The following is a description of a gene set: Human Gene Set: MIR600 species: Homo sapiens from publication Chen Y, Wang X (PMID 31504780) Genes predicted to be targets of miRBase v22 microRNA hsa-miR-600 in miRDB v6.0 with MirTarget v4 prediction scores > 80 (high confidence targets)., and this is the list of marker genes: ELF2, ZBTB41, KCTD21, GAD1, TDRP, RAP2C, BBX, INA, RANBP3, RFPL1, MYT1L, KDM5A, RAB10, STK4, ATF3 (activating transcription factor 3), PHTF1, KDM5B, LHX8, NF1, ALS2, DZIP1L, NKIRAS2, FOXC1, NRBF2, TRIM52, MIA2, NCL, MEAF6, NUDT5, COL11A1, TTC22 (NCBI Gene Id 55001), SHLD2, NKX2-5, SLC6A6, PCMTD2, TMPRSS11D, PCF11, PDE1A, HIVEP3, STX6, RAB4A, USP27X, ZNF451, KCTD12, ARL1, CLASP2, PAFAH1B1, UBQLN1, STRIP2, CCNJ, RNF125, SCFD2, SLC2A10, PEAK1, WRN, TIAM2, RICTOR, ETNK1, STIM2, CLVS2 (NCBI Gene Id 387358), VGLL3, ZC3H12B, UCHL1, NEMP1, NAA35, SERINC5, PCDH7, RFPL3, PALLD, CRH, MBD2, GLI3, KMT2E, NPY2R, KIAA0930, SP3, ARPP19, DCLRE1B, UBR3, KLF9, WAC, HAPLN1, CCNDBP1, ZNF792, UBQLN2, EPHX2, PPP2CA, WASHC3, TNRC6B, CREBBP, MMS22L, PTPRD, CPSF6, CIP2A, NACC1, SLC6A2, PCDH8, KCNA4, ATP6V0A2, BICRA, SHPRH, NOVA1, SPSB1, ZC3H12C, DCUN1D1, PRKACB, ENAH, CRIM1, DDIT4L, DYRK2, C8orf34 (chromosome 8 open reading frame 34), SLITRK5, C2orf88, CCK, TP53I11, NETO1, KCNE3, GDAP1, PHTF2, ZSCAN31, RPS6KC1, GATA3, EPS15L1, DLC1, UBFD1, ABRAXAS2, FEM1B, SEPTIN3, ZNF804A, PTBP3, INSIG2, COL2A1, HPRT1, SLC4A10, LONRF2, FMNL3, SBNO1, INSM2, THAP5, NSG1, SPIN1